The following is a description of a gene set: Mouse Gene Set: GOBP_VENTRAL_SPINAL_CORD_DEVELOPMENT The process whose specific outcome is the progression of the ventral region of the spinal cord over time, from its formation to the mature structure. The neurons of the ventral region of the mature spinal cord participate in motor output. species: Mus musculus, and this is the list of marker genes: Lhx1, Dbx1, Pax6 (NCBI Gene Id 18508), Abt1, Dctn1, Mir19a, Evx1, Ighmbp2, Ift172, Olig2, Mir92-1, Lmo4 (LIM domain only 4), Phox2a, Hoxd10, Cln8, Olig3, Gbx1, Isl1 (NCBI Gene Id 16392), Dmrt3, Vstm5, Lhx1os, Gigyf2 (NCBI Gene Id 98689), Cacna1a, Mir19b-1, Nfe2l1, Ptch1, Scyl3, Gli3, Vldlr, Gata2, Foxn4, Lhx3, Nkx6-2, Mir20a, Nkx6-1, Reln, Dll4, Mir18, Mir17, Scyl1, Lrp8, Shh, Dync2h1, Foxp1, Gli2, Mnx1, Dab1, Lbx1, Isl2, Dicer1, Tctn1, Tbx20, Nkx2-2 (NK2 homeobox 2), Hoxc10, Gdpd5, Lonrf2, Ascl1, Lhx4, Sox1, Zc4h2, Sufu